The following is a description of a gene set: Human Gene Set: WP_BIOMARKERS_FOR_PYRIMIDINE_METABOLISM_DISORDERS Biomarkers for pyrimidine metabolism disorders species: Homo sapiens, and this is the list of marker genes: DPYS, UPB1, UMPS, RRM2, RRM1, RRM2B, DPYD, NT5C3A, TYMS, PUS1, CKB, DHODH, TYMP, TK2, NT5C